The following is a description of a gene set: species: Homo sapiens mouse primary BMDCs were stimulated with tlr ligands and gene expression changes were profiled on Affymetrix arrays Human Gene Set: GSE17721_LPS_VS_GARDIQUIMOD_4H_BMDC_DN Genes down-regulated in comparison of dendritic cells (DC) stimulated with LPS (TLR4 agonist) at 4 h versus DC cells stimulated with Gardiquimod (TLR7 agonist) at 4 h. from publication Amit I, Garber M, Chevrier N, Leite AP, Donner Y, Eisenhaure T, Guttman M, Grenier JK, Li W, Zuk O, Schubert LA, Birditt B, Shay T, Goren A, Zhang X, Smith Z, Deering R, McDonald RC, Cabili M, Bernstein BE, Rinn JL, Meissner A, Root DE, Hacohen N, Regev A (PMID 19729616), and this is the list of marker genes: BTK, MROH1, ID3, BBLN, MEF2D, MARCO, WNT2B, CD99L2, COPRS (NCBI Gene Id 95076), TTC3, FUBP1, SDC1, HES6, PJA2, UCKL1, TSPAN6 (tetraspanin 6), INPP5A, POFUT2, CXCL6, ARHGAP5, TTC13, MRPL37, RGS3, RMC1, GTF3C4, TMED7, SUPT16H, PCLAF (PCNA clamp associated factor), REEP1, PPBP, ELP1, YWHAG, SMARCAL1, CDCA5, ACOX3, EVI5, DDX18, PAG1, MNT, RPS2, PDF, MIDN, CIAO2B, MAPRE1, BYSL, SMARCC1, DCTN5, SNX12, IPPK, PPP1R3F, CDIP1, CAPS2, PGAP6, PPP3R1, IPO9, SAA1, MTG2, HEATR6, RAB31, SUGP2, MRPL51 (mitochondrial ribosomal protein L51), TOPBP1, TLL2, FNTA, EIF4B, UIMC1, MRPL46 (mitochondrial ribosomal protein L46), TSC1, HDHD2, SCYL1, CUL4A, SGSM3, HEPACAM2, WSB1, PSMD12, VASP, SHISA2, MLLT11, CFAP20, TSC22D4, TRMT10B, RHOG, C14orf119, FECH, TOMM20, PDCD6, FARSB, RGS19, LDAH, FAM98A, TMEM185A, POLD1, KIF3C, POLR3D, SDF4, VPS11, DUOXA1, ANP32B, ZNF808, EXOC1, FAM216A, C18orf32, CERK, NSMF, PTPN9, GPN1, RRAD, GPNMB, INTS6L, ERO1A, HSD17B12, CYRIB, UBA2, CHTF8, RPL3, PLA2G15, ZCCHC8, LRRIQ4, EIF2S3, ARMC1, NCF2, PRMT5, OGFOD3, IER3, POLR2I, POLD4, SLC30A5, B4GALT1, MEA1, CASD1, NR2C2AP, SF3A2, MAP3K14 (mitogen-activated protein kinase kinase kinase 14), SLC2A1, SDHD, WDR4, IARS1, KGD4 (NCBI Gene Id 92259), MMACHC, MYO7A, RNF7, B3GALNT2, KLHL7 (NCBI Gene Id 55975), MRPS33, FAM184B, EGF, CTSB, ATG2B, ZSCAN26, MTRES1, IVNS1ABP, TESK2, PFN1, LONP2, SF3A1, USP10, SNX15, SEMA4B, IKZF2, AFG1L, FZR1, NOS3, QNG1, TBPL1, MEMO1, SLC25A38, ECI1, PTCD2, NEU1, SEC24D, PPP4R1, MEF2A, VAC14, EIF5, SPIDR, DYNLRB1, P2RY6, PACS2, EMC7, RDH13, NOPCHAP1, LDHA, SLC19A2, PEDS1, NDRG4, SEC14L1, IRF4, SRSF6, CLK2, MYO9B, UNC119, CIPC, C12orf43, YIF1A, NATD1, ZNF146, GCLC, BCDIN3D, TTK